The following is a description of a gene set: Any process that activates or increases the frequency, rate, or extent of leukocyte mediated immunity. species: Homo sapiens Human Gene Set: GOBP_POSITIVE_REGULATION_OF_LEUKOCYTE_MEDIATED_IMMUNITY, and this is the list of marker genes: SLAMF6, RAET1L (retinoic acid early transcript 1L), NCR3, RAET1G, HLA-C, CD1A, CD28, TYROBP, TRAF2, MAD2L2, IL4, SH2D1B, KLRC3, SHLD3, SHLD2, IL12B, CD1E, TGFB1, HLA-H, TREM2, DENND1B (NCBI Gene Id 54530), STAT6, KIT, IL23A, IL2, ULBP3, LAMP1, FCER1G, NLRP3, IL1R1, TP53BP1, KLRC4-KLRK1, SPI1, KLRC4, STAT5B, SHLD1, KLRK1, KLRC2, CAMK4, DHX36, NOD2, FCGR1A, RSAD2, ITGAM (integrin subunit alpha M), MALT1, ULBP1, HMCES, B2M, RASGRP4, TFRC, ATAD5, KMT5C, RIGI, IL18R1, IL21, F2RL1, AZGP1, KLHL22, CD1C, TNFSF13, PVR, GATA3, KMT5B, CD7, CLEC7A (NCBI Gene Id 64581), STX4, TICAM1, KIR2DL4, NECTIN2, PLCG2, NSD2, LAG3 (lymphocyte activating 3), SLC22A13, CD55, C17orf99, POMC, MAVS, MSH2, TNF, TNFSF4, ARID5A, PRKAA1, HLA-DRB3, RIF1, LTA, ULBP2 (UL16 binding protein 2), HLA-E, TBX21, AP1G1, CYRIB, PAXIP1, CADM1, HLA-F, SH2D1A, CD177, STAT5A, SCIMP, ITGB2, MR1, CD1D, PRKCZ, HLA-G, P2RX7, IL12RB1, TRAF6, CD81, STX7, FOXP3, IL18RAP, SASH3, DDX1, HLA-B, IL23R, FZD5, IL6, HPX, FADD, HLA-DRB1, BTK, HLA-DRA, PTPRC, HLA-A, DDX21 (NCBI Gene Id 9188), MLH1, RAET1E, PMS2, RASGRP1, CLNK, CD1B, CD40, CD160, CLCF1, MAP3K7, C3 (complement component 3), STAP1, SLAMF1, FBXO38, FCER2, HSPD1, KLRD1, XCL1, EXOSC3, CRTAM, KLRC1, ZBTB1, YWHAG, ZP3, EXOSC6, SECTM1, IL1B, CD226, VAV1, IL12A, ARG1, TAP2, NOS2, IL18